The following is a description of a gene set: studied in species Homo sapiens Human Gene Set: GOBP_POSITIVE_REGULATION_OF_NEURON_APOPTOTIC_PROCESS Any process that activates or increases the frequency, rate or extent of cell death of neurons by apoptotic process., and this is the list of marker genes: AIMP2, CASP2, NR3C1 (NCBI Gene Id 389335), MCL1, APP, BACE1, CASP6, ITGA1, NOS1, CASP5, TP53, NF1, CASP12, NFATC4, CASP3, CASP4, NUPR1, FIS1, PRNP, FBXW7, RAPSN, DDIT3, BAX (NCBI Gene Id 581), HDAC3, GRIK2, TFAP2B, ADCY10, CASP14, CASP10, POU4F1, ATF4, PHB1, GSK3B, LCN2, CCL3, ST8SIA2, CASP7, FOXO3, BCL2L11, SRPK2, CDK5R1, BBC3 (NCBI Gene Id 27113), MYB, HRK, PCSK9, TNF, ASCL1, PITX3, CDK5, CTNNB1, TRAF7, MMP2, CFLAR, MIR98, AIFM1, ABL1 (ABL proto-oncogene 1, non-receptor tyrosine kinase), MAP3K11, RIPK1 (receptor interacting serine/threonine kinase 1), CASP9, FASLG, HTR2A, EPHA7, TFAP2A, MIR200A, GSK3A, CASP8, GRN, TGFB2, ATM